The following is a description of a gene set: studied in species Homo sapiens Human Gene Set: MIR6829_3P from publication Chen Y, Wang X (PMID 31504780) Genes predicted to be targets of miRBase v22 microRNA hsa-miR-6829-3p in miRDB v6.0 with MirTarget v4 prediction scores > 80 (high confidence targets)., and this is the list of marker genes: ZZZ3, ANKRD16, ABHD11, SRGAP3, GPX7, ATP1B1, XRN1, PRKCB, DDX6, TSN, MRTFB, ARIH1, NPAS3, BNIP3L, CCK, DNAJC18, BAGE2, ZNF69, DSTYK, CUX2, GSTM4, RAP2B, NAV3, ZC3H4, EYA3, B4GALT2, FKTN, ATP6V0B, ZFP1, MTCL2, LILRB4, NR4A3, KIAA1549L, TK2, ZNF341, KLHDC7A, ADARB2, MAPK14, PPFIA2, ADAM10, SEMA5B, NR3C1, FAM20A, NFIB, SLC16A9, TENT4A, TTC23, SLC52A3, SYN3, ORAI2, SNX1, ZNF786, FSD2 (NCBI Gene Id 170466), TIMM17A, CHD6, TMEM104, FRMPD4, CHST2, ARNT2, FNBP1, SERINC1, IQSEC3, PROX1, CAMLG, ST6GAL2 (NCBI Gene Id 84620), KSR2, RPGR, KLHDC10 (NCBI Gene Id 23008), TEF, SOWAHB, C5orf24, PCDHA2, VPS26B, PRDM16, THSD7A, DTX3L (NCBI Gene Id 151636), ZNF704, PTPRO, CD1C, MYRIP, ESF1, P2RY13, SLC15A1